The following is a description of a gene set: The directed movement of an organelle along a microtubule, mediated by motor proteins. This process begins with the attachment of an organelle to a microtubule, and ends when the organelle reaches its final destination. Mouse Gene Set: GOBP_ORGANELLE_TRANSPORT_ALONG_MICROTUBULE species: Mus musculus, and this is the list of marker genes: Wasf1, Cdc42, Kxd1, Arhgap21, Bloc1s4, Dtnbp1, Mreg, Fyco1, Lamp1, Hif1a, Ap3d1, Rab1a, Trim58, Trim46, Borcs5, Borcs8, Madd, Ap3m1, Actr10, Rhot2, Kif5a, Pafah1b1, Snapin, Hdac6, Pex14, Ap3b2, Bloc1s3, Fbxw11 (NCBI Gene Id 72380), Kif1c, Armcx3, Tuba1a, Syne2, Agtpbp1, Ndel1, Uchl1, Nefl, Nefh, Ap3s2, Trak1, Hsbp1, Map6, Spg11, Map2, Mgarp, Kif13a (NCBI Gene Id 328239), Ap3m2, Ubb, Ap3b1, Cln3, Rhot1, Dync1i1, Map1b, Tmem201, Kif28, Kif5b, Fez1, Agbl4, Kif16b, Kif1b, Kifc1 (kinesin family member C1), Mecp2, Trak2, Cnih2, Htt, Stk11, Hap1, Sybu, Map2k1, Bloc1s5, Borcs6, Kif1a, Bloc1s2, Bicd2, Sun1, Bloc1s6, Spast, Borcs7, Bicdl1, Copg2, Bicd1, Bicdl2, Bloc1s1, Ap3s1, Kifbp, Nde1, Rasgrp1, Prkcz, Mapt, Sun2, Copg1